Given this list of marker genes GLDN (NCBI Gene Id 342035), DSC2, IZUMO1, DSG2 (NCBI Gene Id 1829), CD200, DSP (desmoplakin), JUP, PKP2, CD47, SIRPA, CXADR (CXADR Ig-like cell adhesion molecule), NRCAM, here is a description of the gene set: Binding to a protein or protein complex contributing to the adhesion of two different types of cells. Human Gene Set: GOMF_PROTEIN_BINDING_INVOLVED_IN_HETEROTYPIC_CELL_CELL_ADHESION studied in species Homo sapiens